The following is a description of a gene set: studied in species Mus musculus Mouse Gene Set: GOBP_REPRODUCTIVE_PROCESS A biological process that directly contributes to the process of producing new individuals by one or two organisms. The new individuals inherit some proportion of their genetic material from the parent or parents., and this is the list of marker genes: Spin1, Mmp2, Rsph6a, Igfbp5, Clasp2, Nlrp5, Lepr, Btbd35f1, H1f6, Wdr48, Asb1, Pank2, Srd5a2, Ovgp1, Ncaph, Hnrnpk, Rarg, Hsd17b4, Mir449b (NCBI Gene Id 100190765), Vmp1, Abcb1a, Spata20, Brdt, Mgat4d, Kdm1b, Sohlh2, Dmrt3, Hspa1b, Egfr, Siah1a, Cts7, Tut7, Krt19, Arrb1, Aaas, Fbln1, Ints13, Npm2, Nos3, Tsx, Txndc2, Usp42, Cfap47, Slc2a1, Bcap31 (B cell receptor associated protein 31), Eif2s3y, Wnt4, Drd4, Izumo1r, Bcl2, Sly, Sirt2, Insrr, Eaf2, Ooep, Cftr, H3f4, Cdc25a, Ptgdr2, Prss37, Sod1 (NCBI Gene Id 319325), 4930447C04Rik, Vdr, Ttc12, Zfp296, Tnk2, Mir741, Dsg2, Nos2, Ndrg3, Erbb2, Iqcg, Ggt1, Itih5, Numa1, Spag6l, Hoxd11, Inpp5b (NCBI Gene Id 16330), Mirlet7c-1, Sufu (NCBI Gene Id 72652), Yif1b, Ift81, Rad54b, Fbxw11, Vip, Gata4, Dnaaf3, Katnal1, Mettl3, Spata2, Galntl5, Spaca3, Csmd1 (CUB and Sushi multiple domains 1), Gli1, Nobox, Rln1, Slxl1, Ubtfl1, Rimbp3, Spinkl, Ptafr, Cfap45, Lep, Ace, Enpp2, Ren1, Dnah1, Llcfc1, Lfng, Snai1, Lrrk2, Rac1 (NCBI Gene Id 52352), Smurf2, Tac4, Tcf7, Nhlh2, Morc1, Ptgs2, Gm17266, Fbxo5, Parp1, Mbd2, Stc2, Prmt7, Spag1, Exd1, Mir184, 3830403N18Rik, Cep131, Parp2, Senp2, Psapl1, Tnfsf10, Mapk8ip2, Pkdrej, Gja1, Amhr2, Ctsb, Zpbp2 (NCBI Gene Id 69929), Kdm2b (NCBI Gene Id 30841), Acvr1c, Mamld1, Spam1, Kat8, Odf1, Tut4, 1700013H16Rik, H2ax, Gmnc, Prss55, Hsd11b2, Jam3, Dazl, Adam25, Ppard (NCBI Gene Id 69050), Cbx2, Efhc1, Drd1, Herc2, Efhc2, Spire2, Dnhd1, Cfap52, Lrrc52, Diaph2, Csf1, Aurkc, Aplp2, Cfap20, Septin4, Acr, Gm28510, Vps54, Cfap43, Zfp830, Htt, Pkmyt1, Smad5, Ccnb2, Hoxa9, Prl, Psmd13, Gnas, Ak7, Mdk, Fst, Spata6l, Mov10l1, Krt8, Svs3b, Nectin3, Tpgs1, Adam18, Tial1, Glra1, Pafah1b2, Adam34l (a disintegrin and metallopeptidase domain 34 like), Eif2s2, Ago2, Gli2, Rara, Fshr, Lhx1, Nicol1, Hspa2, Lif, Dusp21, Txnrd3, Tcf21, Paqr7, Dmc1, Dcst2, Rai14, Mir144, Glipr1, H1f1, Gm29866 (predicted gene, 29866), Frs2, Sox9, Sry, Sfrp2, Amh, Tdrp, Adam15, Iqcn, Uprt, Galnt3, Foxa3, Mast2, Nup107, Haspin, Timp1, Cd9, Cfap97d1 (NCBI Gene Id 75437), Rps6, Bak1, Rad51, Mir143, Mir880 (NCBI Gene Id 100124480), Dhx37, Ereg, Prm3, Crisp3, Slc22a16, Ttll3, Itpr1, Adm, Gk2, Tex12, Ncoa3 (NCBI Gene Id 99361), Atr, Itga3, Dcst1, Ntrk1, Pnma5, Il1a, Lztfl1, Mst1, Gm7958, Cxcl12, Mirlet7a-1, Enkur, Bnc1, Akap9, Klk14, Ercc4, Stat5a, Kdm5a, Gm4787, Dnali1, Mcm6, Ddx3x, Gm5935, Dmd, Prl2c5, Tssk1, Mns1 (meiosis-specific nuclear structural protein 1), Ddo, Ermp1, Itgb4, Rxfp1, Ccno, Mir21a, Cga, Schip1, Cfap54, Met, Eif4g3, Tac2, Tbx3, Adnp, Chtf18, Nrk, Nphp1, Adcy3, Ythdf2, Klhdc3, Syde1, Slc9a8, Sirt7, Ube2b, Kit, Ppp2ca, Gip, Pla2g4a, Pou4f2, Adam20, Mir34c, Cfc1, Sox17, Dydc1, Prkacb, Rnf212, Ldoc1, Smarcc1, Cip2a, Lrrc8a, Stk3, Ccdc136, Hsf5, Paqr5, Epc1, Spag17, Cfap141 (cilia and flagella associated protein 141), Jam2, Gas2, Sp1, Prl3a1, Rbmyf1, Kdr (NCBI Gene Id 269657), Antxr2, Dnajb6, Spink1, Klf17, Cenpe, Ccnd1, Ddb1, Tektip1, Mroh2b, Rad21l, Cfap91 (cilia and flagella associated protein 91), Top2b, Irf2bpl, Bsph2, Prl7d1 (prolactin family 7, subfamily d, member 1), Pygo1, Dnah11, Scx (NCBI Gene Id 20289), Mir138-2, Epo, St14, Bok, Tlk2, Srd5a1, Dbh, Ankrd31, Grk2, Tekt2, Ankle1, Tdrd12, Cfap119, Mael, Trip13, Agt, Ythdf3, Lhb, Rnase9, Ccnb1, Cfap90, Spata19, Qrich2, Stk4, Xrn2, Hesx1, Epn1, Adam24, Trp63, Xlr5a, Lgr5, Adcyap1r1, Cetn2, Dicer1, Atp2b4, Armc12, Drd5, Klhl10, Gm10230, Elf5, Lhfpl2, Sass6, Dld, Zc3h14, Pdik1l, Cadm1, Fkbp4, Ddx25, Pldi, Gfra1, Saxo4, Dnmt3a, Serpine1, Runx1, Cntrl, Syce3, Tcf7l2, Stau1, Poc1a, Zfp541, Zfpm2, Hook1, Sp3, Bik, Ubap2l, Itgb3, Cabyr, Rbx1, Plcd4, Mirlet7c-2, Septin6 (NCBI Gene Id 80615), Tesmin, Sohlh1, Plb1, Ncoa1, Tmed2, Hoxb13, Serpinb6a, Stau2, Jmjd1c, Large1, Figla, Fgf7, Dcaf13, Exoc1, Cd46, Cntfr, Ovol1, Syce1, Rnf212b, Lhx9, Catsperd, Defb1, Fos, Adgb, Lrriq1, Hmgb2, Fbxo43, Zwint, Crem, Spire1, Rab1a, Gnpda1, Garin1a, Actl9, Bmp8b, Spata6, Spaca6, Msh2, Zscan4b, Gjb3, Hoxa11, Cfap144, Ddx3y, Spag4, Arrdc5, Zmynd10 (NCBI Gene Id 114602), Suv39h2, Dmrta2, Rsph1, Slc38a1, Septin7, Acvr2a, Hfe, Rnf151, Slit3, Dnah5, Izumo1, Mfsd14a (major facilitator superfamily domain containing 14A), Glipr1l2, Rxra, Cd44, Pax5, Sh3pxd2b, E2f7, H1f7, Tiparp, Brip1, Dusp1, Crtap, Arid5b, Bbs4, Cecr2, Xlr3c, Lrp6, Dnaja1, Prss44, Esr1 (estrogen receptor 1 (alpha)), Prl7c1, Tesk1, Rabl2, P2rx1, Gh, Nkd1, Smc2 (structural maintenance of chromosomes 2), Trim75, Mir202, Btbd18, Nme8, Rnf114, Zfx, Pld6, Hectd1, Havcr2, Sebox, Prl2c3, Eif2b4, Zfp148, Gopc, Psma8 (NCBI Gene Id 73677), Avpr1a, Osr1, Vps13b, Reck, Tesc, Ascl2, Hoxd9, Mfn2, Sbf1, Glipr1l1, Neurl4, Cnr1, Ghsr, Immp2l, Spatc1l, B4galt1, Pla2g3, Fam209, Mdfi, Errfi1, Syne1, Mkrn2, Mir182, Gm5169, Ptch1, Atat1 (NCBI Gene Id 73242), Bmp7, Msh4, Stat5b, A2m, Shh (sonic hedgehog), Prl3c1, Ldhc, Sox3, Ptprn, Rsph14, Rbm46, Fancg, Spesp1, Foxf2, Slc9c1, Tacr1, Zp2, Cxcr4, Ska3, Pgm3, Nme5, 1700102P08Rik, Rbmy, Adam7, Irag2, Hcn1, Ddias, Fuom, Spata22, Serpina5, Mea1, Skil, Afp, Bend2, Agfg1, Mlh1, Kif9, Adam1a, Prok2, Septin2, Cr1l, Dnaaf6, Dnajc19-ps, Birc5, Ptgds, Bscl2, Grn, Rhobtb3, Bax, Mapk1, Spaca4, Gata3, Rxfp2, Sstr3, Cylc2, Pttg1, Slc22a14, Mug1, Cdkn1c, Prl3d1, Tssk4, Hoxd10, Tlr3, Crh (corticotropin releasing hormone), Trpc3, Gm21996, Ythdc1, M1ap, Slx4, Tmem232, Rab3a, Spmip6, Tssk6, Mas1, Slc25a31, Pkd1, Zmiz1, Gcm1, Tlr9, Tex101, Bcl2l1, Slc9b1, Oprk1, Mfge8, Rbx1-ps, Neurog1, Dzip1, Sfrp1, Ttll8, Sphk2, Atm (ataxia telangiectasia mutated), Adrm1, Slc38a2, Tubgcp6, Ccin, Safb2, Capn2, Mcm7 (minichromosome maintenance complex component 7), Ubb, Cyp1a1, Mcidas, Adcyap1, Slc9b2, Oog1, Ptpn11, Kmt2b, Fgfr2 (fibroblast growth factor receptor 2), Spmap2, Tekt4, Hand1, Bmal1 (basic helix-loop-helix ARNT like 1), Ncaph2, D1Pas1, Cct6a, Sgo2a, Tcte1, Zan, Tdrd9, Adam29, Cdc20, Catspere2, Efcab9, Ptk2b, Zcwpw1, Rfx2, Ccdc159, Ct55, Bcl6, Tex19.2, Akap3, Tcp11x2, Cbs, Mei4, Fndc3a, Rpl10l, Med1, Id4, Apela, Flna, Zfp318, Rnf8, Fanca, Ap3b1, Sema3a, Celf1, Ccdc146, Tbata, Dhx36, Corin, Bmp5, Tubg2, Abhd2, Cdc25c, Nr6a1, Spata31, Tdrd5, Hexb, Sox30, Tead4, Lcn6, Pdilt, Tsnaxip1, Prdm14, Selenop, Pms2, Col6a1, Asmt (acetylserotonin O-methyltransferase), Serpine2, Crkl, Btg1, Tppp2, Axl, Ctdnep1, Ccdc63, Lamp1, Ash1l, Sfmbt1, Arid4a, Slx, Fosb, Garin5a, Hvcn1, Prdm9, Prl8a2, P2ry1, Has2, Trim28, Prlr, Pmfbp1, Styx, Lrp2, Calca, Ica1l, Adipor2, Fancm, Vdac2, Mecp2, Comt, Icam1, Mybl1, Shb, Arsa, H2-Q2, Kmt2c, Cfap44, Efcab6, Prl7a2, E2f8, Fgf10, Utp14b, Igf2r, Rmi1, Armc2, Pgk2, Actl7a, Cntd1, Fzd5, Xlr, Plg, Hnf4a, Catsper1, Pde3a, Angpt2, Prl3d3, Crebrf, Ncapd3, Nppc, Ppp2r1a, Gm29276, Prnd, Dmrt2, Prl3d2, Eqtn, Dach1, Zar1l, Cfap57, Armc3, Il11ra1 (NCBI Gene Id 16157), Cyp51, Bmp4, Wnt3, Gm5934, BC005624, Mir455, Pmp22, Tdrd1, Zmynd12, Six3, Ccdc33, Mcm2, Gja10, Sycp1, Drc1, Gas8, Hadh, Zfp37, Arhgap33os, Catsper2 (NCBI Gene Id 212670), Ccdc34, Hsf2bp, Nog, Hdac2, Nupr1, Tektl1, Wee2, Fancc, Xlr5b, Rxrb, Strbp, Nr5a2, Fzd4, Tsga8, Ptger4, Npas1, Kif18a, Cyp7b1, Sox8, Ncoa2, Gjb2, Sppl2c, Cit, Spata46, Bcl2l11, Hsf2, Ggnbp1, Meikin, Svs3a (NCBI Gene Id 99449), Pltp, Mertk, Syce2, Topbp1, Prkaca, Has1, Avp, Larp7, Stat3, Hrob, Brinp1, Mmp9, Boll, Adam30, Gm10488, Adad2, Cyp1b1, Dmxl2, H3f3b, Mirlet7d, Adam32, Limk2, Spata32, Gm20736, Rbm7, Mir743, Inhbb, Atn1, Slc38a3, Aldoa, Cfap206 (cilia and flagella associated protein 206), Pappa, Spmip9 (sperm microtubule inner protein 9), Adam4, Sptbn4, Kdm3a, Gata6, Ctcfl, Mir124-2hg, Acrbp, Plk1, Tcp11, Sstr1, Adam3, Pcna, Nkapl, Ahr, Gm28576, Folr1, Calr, Adra2a, Akr1c18, Thrb, Bsph1, Tfpt, Sun1, Ppp3r2, Aff4, Tssk3, Clgn, Piwil1, Mir138-1, Cct2, Ddr1, H19, Cct7, Gpx4, Bmp8a, Adam39, Chd7, Ahsg, Cimap1a, Iftap, Catsper3, Slc26a8, Mirlet7b, Mapk15, Gapdhs (NCBI Gene Id 14447), Arrb2, Fut7, Rnf17, Pik3ca, Stox2, Epor, Golga2, Wnt7a, Wdr19, Tmprss12, Atp1a4, Usp26, Tekt1, Tubb4b, Hspe1-rs1, Washc1, Odad3, Cxadr, Gnaq (guanine nucleotide binding protein, alpha q polypeptide), Nlrp14, Racgap1, Mki67, Spint2, Tacr3, Irx5, Gm28870, Cts8, Tex19.1, Terb2, Gm5168, H2bc1, Adad1, Casp2, Taf4 (NCBI Gene Id 98977), Mir183, Clxn, Zscan4a, Ube2q1, Taf4b, Plat, Rnf2, Herc4, Pax2, Mcm9, App, Cep78, Wfdc6a, Tex14, Glipr2, Cfap95, Kitl, Ccr6, Shcbp1l, Gm29554, Itga2, Ttc21a, Adam2, Tuba1a, Csnk2a2, Igf1, Pten, Dnaaf6rt, Rhox5, Gal3st1, Spem3, Sord, Gm1140, Mir193a, Morc2b, Fsip2, Tbc1d20, Park7, Atp8b3, Akap4, Fancf, Pde5a, Izumo3, Gm21627, Defb37 (defensin beta 37), Kiss1, Itgb1, Scaper, Fance, Bmpr2, Chd5, Tssk2, Gjb5, Rec8, Fsip1, Umodl1, Umps, Jag2, Gpr149, Prl2a1, Phb1, Cited2, Pcsk4, Lgr4, Shoc1 (shortage in chiasmata 1), Zmynd15, Lin28a, Ppp3cc, Asz1, Nell2, H3f3a, Taf7l, Gdf7, Fer, Txndc8, Prl8a9, Phc2, Creb3l4, Gm20843, Lrrc23, Rsph9, Incenp, Nme7, Mcm4, Cfap70, 1700028K03Rik, Npy5r, Syce1l, Nrip1, Adam6b, Rbmyf7, Ovch2, Acvr1 (NCBI Gene Id 11478), Arhgdib, Cabcoco1, Agrp, Trpc7, Selenof, Map3k4, Kat5, Crisp4, Tyro3, Folr2, Zfp42, Sprr2d, Rbmyf5, Mycbpap, Ada, Ythdc2, Rps6kb1, Cckbr, Hps1, Spata24, Spmip8, Atrx, Espl1, Npr2, Neurl1a, Dhcr24, Gm2012, Pierce2, H1f8, Six5, Cep63, Adgrg1, Dnd1 (NCBI Gene Id 21746), Xlr4c, Cct8, Trim36, Mstn, Dnmt3b, Sdc1, Zscan2, Meig1, Mcmdc2, Ankrd49, Bmpr1b, Itga5, Fignl1, Gm21095 (NCBI Gene Id 100861637), Cfap276, Sgo1, Zfp35, Pnldc1, Ghrl, Slc22a5 (solute carrier family 22 (organic cation transporter), member 5), Cfap58, Gm21760, Taar5, Nr2f2, Adam21, Thbd, Fam170b, Rad50, Adam1b (a disintegrin and metallopeptidase domain 1b), Gm4297, Gmcl1, Ift88, Ndn, Patz1, Ppp1cc, Myocd, Smc1a, Rgs2, Unc13b, Plcz1, Cenpc1, Sec23ip, Ros1, Mkks, Grin1, Grb14, Irgc, Mir124a-1hg, Cfap161, Unc5c, Fancd2, Ihh, Ints1, Star, Paqr8, Gata1, Sos1, Cfap61, Ccdc62, Plekha1, Pln, Lypd4, Gm28919, Sun5, Prdx3, Fkrp (NCBI Gene Id 243853), Nppa, Catsperg2 (NCBI Gene Id 76718), Pxt1, Eed, Wipf3, Setx, Rbmyf2, Mmp19, Semg1, Pdcl2, Exo1, Th, Rps6ka2, Pcsk5, Dusp3, Pafah1b1, Cfap107 (cilia and flagella associated protein 107), Rrm1, Il11ra3, Bag6, Il11ra2, Tm9sf5, Spdya, Sirt1, Trpc6, Nsun7, Kash5, Golga3, Smc3, Tsix, Smad1 (NCBI Gene Id 17125), Bbof1, Axdnd1, Crisp2, Ift56, Ttll9, Ehmt2, Bmp6, Drc7, Spata25, Cdk2, Cacna1h, Nup62, Orc4, Spmip10, Spaca5, Gsr, Celf3, Hormad1, Rad1, Rad51c, Morn2, Dnai1, Mycn, Plaur, Mir26a-2, Fhad1, Cpeb1, Stag2, C2cd6, Prr19, Foxo3, Prl6a1, Nphp4, Tdrd6, Gm21294, Stc1, Pde4d, Fgf8, Gm28961, Cabs1, Snu13, Hoxa10, Ggn, Hnf1b, Eif2b5, Fbn2, Endou (NCBI Gene Id 19011), Hyal3, Pafah1b3 (platelet-activating factor acetylhydrolase, isoform 1b, subunit 3), Ptx3, Pias1, Tgfb2, Nectin2, Psg17, Eif4h, Gli3, Cfap157, Phb2, Nanos3 (nanos C2HC-type zinc finger 3), Mcm8, Ttll1, Afg2a, Tac1, Prm2, Abl2, Vmn2r116, Ccl2, Ube2a, Rnase10, Tbc1d21, Gabrb1, Brme1, Foxc1, Bsg, Mcm3, Rbmyf3, Tnc, Lhx8, Stxbp1, Gal, Prss28 (NCBI Gene Id 114661), Mir881 (NCBI Gene Id 100124460), Cad, Pum1, Cfap251, Tpst2, Kcne1, Rpa1, Notch1, Pfn4, Mir135a-1 (microRNA 135a-1), Ska2, Mos, Map2k6, Chrna7, Spata33, Dach2, Alms1, Prl8a1, Eme2, Tcp1, Insl6, Gm21865, Gabrb3, Fem1b, Cnot7, Zfp57, Zpbp, Ace2, Iqch (NCBI Gene Id 78250), Spef2, Smad4, Garin5b, Dhh, Hormad2, Ctcf, Six4, Cyp26b1, Xlr3b, Mir742 (NCBI Gene Id 100049548), Wfdc6b, Oxtr, Agfg2, Mettl14, Acvr1b, Ercc1, Gm14525, Acox1, Iho1 (NCBI Gene Id 434438), Glrb, Ppp1r9b, Adra2c, Ccdc39, Areg, Herpud2, Fcrl5, Tsnax, Foxj3, Cct4, Bltp1, Cfap210, Nkx2-1, Nefh, Junb, Hnf1a, Klf9, Garin1b (golgi associated RAB2 interactor 1B), Stra8, Ptgdr, Cd2ap, Cdkn1b, Prkdc, Ybx3, Efhb, Cfap65, Spag6, Tug1, Uchl1, Ddx20, Rhox8, Psmc3ip, Tdrkh, Adra2b, Gm20817, Rbmyf8, Cast, Dmrtb1, Zdbf2, Gnasas1, Ctnnb1, Gm20820, Dmrt1, Zfp628, Ttk, Ccnb3, Adcy10, Mir471, Tubgcp4 (tubulin, gamma complex component 4), H1f9, Ror2, Spink2, Mastl, Nanos1, Septin1, Edn2, Frey1, Cfap69, Itgav, Spaca7 (sperm acrosome associated 7), Dnmt3l, Prl2c2, Dedd, Spem1, Alpl, Ccdc38, Smchd1, Cldn4, Mir26a-1, Pygo2, Gm20824, Hpgd, Il1b, Rsl1, Foxa1, Nuf2, Igf1r, Rab13, Tesk2, Top6bl, Prss42, Zfp449, Tmem81, 4930451I11Rik, Slco4c1, Dkkl1, B4galnt1, Mre11a, Nek2, Vps13a, Wdr54, Zp3, Clic4, Etv5, Sts (NCBI Gene Id 20905), Abat, Sulf1, Dlec1, Ropn1l, Bbs2, Ube3a, Tle3, Slirp, Ybx2 (Y box protein 2), Xist, Prdx4, Chfr, Slc4a2, Dnajb13, Ropn1, Spag8, Mir672 (microRNA 672), Hexa, Rad51d, Osbp2, Washc5, Ska1, Fam170a, Plcb1, Prl2c1, Nr2c2, Nanog, Krt9, Ube2j1, Smc1b, Spo11, Tarbp2, Magoh, Fzr1, Alkbh5, Tle6, Hmga2, Gm2030, Fgf9, Smc4, Nsun2, Pierce1, Acsbg2, Inhba, Shbg, Lyzl4, Prl8a8, Mir135a-2, Gm773, Pmis2, Tmem95, Tnfaip6, Adamts1, Airn, Nipbl, Syt8, Dpy19l2, Sycp2, Spin4, Gtsf1, Nlgn4l, Fosl1 (NCBI Gene Id 14283), Zfy2, Meg3, Stk11, Dlg1, Xrn1, Spmip5, Sult1e1, Prl8a6, A1cf, Slc26a3, Spag16, Garin4, Vgf, Cfap68, Smad9, Serpinb5, Fev, Topaz1, Rbmyf9, Wbp2nl, Eno4, Majin, Cimip2a (ciliary microtubule inner protein 2A), Cox7b2 (cytochrome c oxidase subunit 7B2), Gsk3a, Dmrta1, Gm20870, Tmem119, Zbtb16, Hpgds, Npas3, Prl5a1, Oca2, Nanos2, Rbbp8, Camk2b, Slc6a4, Rgn, Apob, Cct3, Tacr2, Aspm, Dmrtc2, Spaca1, Mta2, Ssh2, Tbpl1, Acod1, Cyp19a1, Prss29, Sstr2, S100a11, Rpl39l, Bbs1, Rad23b, Knl1, Mir878, Vegfa, Prss43 (serine protease 43), Ccna1, Hmx3, Mir34b, Tubgcp5, H2-Q7, Hoxa13, Ttll5, Prl2b1, Ribc1, Etv6, Cyp27b1, Sf1, Insl3, Nr0b1, Osm, Igfbp2, Psg22 (pregnancy-specific beta-1-glycoprotein 22), Cldn11, AU040320, Edn1, Adig, Fbxo24, Serpinf1, Zglp1, Mapk3, Rdh10, Or4m1, Pzp, Aplf, Men1, Iqub, Spata16, Cdc25b, Ift25, Mir449c, Bcl2l2, Fshb (NCBI Gene Id 14308), Syt6, Fxr1, Psme4, Tuba8, Chn2, Ly6k, Tex11, Stag3, Pgr, Stra6, Rbp4, Erf, Tmem203, Foxj2 (NCBI Gene Id 60611), Nr3c1, Rspo1, Wnt2b, Rec114, Sun2, Piwil2, Mir449a, Cimip2b, Marf1, Meioc, Tslrn1, Brca2, Rad54l, Lrrc46, Tmf1, Cfap221, Smcp, Ift20 (intraflagellar transport 20), Casp3, Smad2, Ccdc40, Oosp2, Bcas2, Scmh1 (sex comb on midleg homolog 1), Pcyt1b, Fkbp6, Prm1, Eomes, Trp53, Prl7a1, Cep128 (centrosomal protein 128), Catspere1, Crisp1, Ago4, Fetub, Poc1b, Oas1d, Foxl2, Greb1l, Kdm5b, Tgfb1, Fancl, Tssk5, Stk35 (serine/threonine kinase 35), Yy1, Rhbdd1, Cacna1e, Mcm5, Astl, Stk33, Bub3, Spin2c, Emp2, Meiob, Xlr4a, Slc19a2 (solute carrier family 19 (thiamine transporter), member 2), Tifab, Prl4a1, Ssty1, Psap, C1qbp, Asb17, Cdk16, H2al2a, Cuzd1, Tppp3, Wnt5a, Tubgcp2, Prkg1, Nup210l, Kctd19, Cbl, Stx2, Gm1993, Gnrh1, Tdrd7, Pla2g10, Ribc2, Pebp1, Cyp11a1, Mmp12, Tnp2, Ccne1, Spata9, Ing2, Fmn2, Arid1a, Ctnna1, Gamt, Terf1, Mirlet7a-2, Cfap126, Kpna6, Ctsl, Dazap1, Cdh1, Hyal5, Hoxd13, Spaca9, Rbmyf6, Upf3a, Pabpc1l, Oxt, Polr1b, Gm21858, Misfa, Tgm4 (transglutaminase 4 (prostate)), Odf4, Glipr1l3 (GLI pathogenesis-related 1 like 3), Usp17le, Garin2, 2610005L07Rik, Gpr3, Bckdk, Ncapd2, Cib1, Cd38, Angpt1, Arid4b, Kmt2d, Calr3, Cks2, Mnd1, Casp4, Abcg2, Clock, Xlr4b, Zfp41, Src, Lamb1, Tekt5, Hsf1, Smad3, H2aj, Mus81, Prl3b1, Spmip7, Zar1, Lrguk, Gdf10, Hspa8, Egr1, Tex15, Wt1, Anxa5, Plk4, Cfap53, Msx1, Cdyl, Cntln, Rb1, Catsper4, Tcf23, Qki, Cimip2c, Nudt1, Ndp, Inha, Esp22, Shisa6, Top2a, Garin3, Lyzl6, Ednra, Kcnu1, Myh9 (myosin, heavy polypeptide 9, non-muscle), Gm21117, Lhcgr, Zp1, Map7, Gm6121, Ccdc182, Kalrn, Ccne2, Zfp39, Tnp1, Mtor, Spa17, Cep57, Ccnb1ip1, Cul4a, Redic1, Cylc1, Retn, Nek1, Ar, Tspan8, Hdac4, Pitx2, Hus1, Aurka, Catsperb, C3, Dcaf17, Adcy7, Gm28102, Grhl2, Ezhip, Cenps, Sox15 (SRY (sex determining region Y)-box 15), Sgpl1, Nbn, Slc26a6, P2ry2, Ccdc42, Cenpx, Prl7b1, Apc, Prdm1, Actr3, Catsperz, Hfm1, Nodal, Ccdc87, Dnajc19, Adam34, Lgals9, Fscn3, Hspa1l, Snrpa1, Lsm14b, Paip2, Xlr5c, Ggnbp2, Zp3r, Cct5 (chaperonin containing TCP1 subunit 5), Rims1, Pgam2, Esp1, Insr, Ndc80, Dpcd, Gsk3b, Gm38999, Spink13, Ift27, Nkx3-1, Vdac3, Prss21, Msh5, Dnaaf11, Trpc2, Adam26b, Adam5, Rsph3b, Tgfbr1, Ednrb, Hmga1, Adam6a, Nr5a1, Acsl4, Pacrg, Rad18, Gm20911, Mapk1ip1, Leat1, Terb1 (telomere repeat binding bouquet formation protein 1), Tekt3, Cebpb, Antxr1, Plag1, Ccnyl1, Spocd1 (NCBI Gene Id 635600), Parp11, Adamts2, Hus1b, Ucn, Tubgcp3, Tmem184a, Ptn, Mmp14, Tubg1, Akt1, Maged2, Oprm1, Iqcf1, Pdgfra (NCBI Gene Id 231312), Ddx4, Duox2, Mir20a, Esr2, Pbx1, Meiosin, Khdrbs1, Bmpr1a, Cnbd2, Crhbp, Piwil4, Msh6, Slc19a1, Zscan21, Ubr2, Kcnq1ot1, Adamts16, Vipas39, Ndc1, Eif2b2, Gdf9, Eme1, Actr2, Odf2, Eppin, Mir96, T, Rad51ap1, Thra, Wnt9b, Msx2, Xlr3a, Mlh3, Wdr77, Mei1, Ptgis, Adam26a, Sox2, Il18, Hoatz, Pithd1, Ppp1r1b, Septin14, Sycp3, Gorasp2, Gm20890, Klc3, Idh1